The following is a description of a gene set: Genes up-regulated in peripheral blood mononuclear cell stimulated vs unstimulated in adults (37-48) after exposure to HIV-LIPO-5, time point 14W. Comment: genes with a significant variation at W14 after 24-h HIV-LIPO-5 stimulation, IFN-gamma, CXCL9, IL2RA, TNFAIP6, CCL3L1 and IL-6 were overexpressed with a fold change |FC| >1.8 OBJECTIVE: To dissect the biological mechanisms involved in the cellular responses to a candidate vaccine containing 5 HIV peptides coupled to a palmytoil tail (HIV-LIPO-5) in healthy volunteers, by using extensive immunogenicity assessments with different stimulation durations. DESIGN: Immunogenicity substudy of a randomized phase II prophylactic HIV vaccine trial (ANRS VAC 18). METHODS: HIV-LIPO-5 or placebo was administered at W0, W4, W12 and W24. Peripheral blood mononuclear cells from a subset of participants at W0 and W14 were stimulated with HIV-LIPO-5, Gag peptides contained in the vaccine and control peptides. ELISpot, lymphoproliferation, intracellular cytokine staining (ICS), cytokine multiplex and transcriptomic analyses were performed. Different time points and stimulation conditions were compared, controlling for test multiplicity. RESULTS: Cultured ELISpot and lymphoproliferation responses were detected at W14. Ex-vivo ICS showed mainly interleukin (IL)-2-producing cells. Secretion of interferon (IFN)-gamma, tumour necrosis factor (TNF)-alpha, IL-5 and IL-13 increased significantly after culture and Gag stimulation at W14 compared to W0. Metallothionein genes were consistently overexpressed after HIV-LIPO-5 stimulation at W0 and W14. At W14, significant probes increased substantially, including IFN-gamma, CXCL9, IL2RA, TNFAIP6, CCL3L1 and IL-6. Canonical pathway analyses indicated a role of interferon signalling genes in response to HIV-LIPO-5. CONCLUSION: HIV-LIPO-5 vaccination elicited Th1 and Th2 memory precursor responses and a consistent modulation in gene expression. The response profile before vaccination suggests an adjuvant effect of the lipid tail of HIV-LIPO-5. Our combined immunogenicity analyses allowed to identify a specific signature profile of HIV-LIPO-5 and indicate that HIV-LIPO-5 could be further developed as a prime in heterologous prime-boost strategies. Human Gene Set: RICHERT_PBMC_HIV_LIPO_5_AGE_37_48YO_STIMULATED_VS_UNSTIMULATED_14W_SIGNIFICANT_VARIATION_UP from publication Richert L, Hue S, Hocini H, Raimbault M, Lacabaratz C, Surenaud M, Wiedemann A, Tisserand P, Durier C, Salmon D, Lelièvre JD, Chêne G, Thiébaut R, Lévy Y, ANRS Vaccine Network/Vaccine Research Institute (PMID 23759749) studied in species Homo sapiens, and this is the list of marker genes: IL6, IL2RA, TNFAIP6, CXCL9, IFNG